The following is a description of a gene set: species: Mus musculus Organic anion transporters Mouse Gene Set: REACTOME_ORGANIC_ANION_TRANSPORTERS, and this is the list of marker genes: Slc5a5, Slc17a1, Slc25a22, Slc5a8, Slc17a6, Slc25a10, Slc25a11, Slc25a1, Slc17a7, Slc17a5, Slc17a8, Slc25a18